The following is a description of a gene set: Cluster d5: genes progressively down-regulated in WS1 cells (fibroblast) through 18 h after irradiation with high dose UV-C. DNA damage caused by UV radiation initiates cellular recovery mechanisms, which involve activation of DNA damage response pathways, cell cycle arrest and apoptosis. To assess cellular transcriptional responses to UVC-induced DNA damage we compared time course responses of human skin fibroblasts to low and high doses of UVC radiation known to induce a transient cellular replicative arrest or apoptosis, respectively. UVC radiation elicited >3-fold changes in 460 out of 12,000 transcripts and 89% of these represented downregulated transcripts. Only 5% of the regulated genes were common to both low and high doses of radiation. Cells inflicted with a low dose of UVC exhibited transcription profiles demonstrating transient regulation followed by recovery, whereas the responses were persistent after the high dose. A detailed clustering analysis and functional classification of the targets implied regulation of biologically divergent responses and suggested involvement of transcriptional and translational machinery, inflammatory, anti-proliferative and anti-angiogenic responses. The data support the notion that UVC radiation induces prominent, dose-dependent downregulation of transcription. However, the data strongly suggest that transcriptional repression is also target gene selective. Furthermore, the results demonstrate that dose-dependent induction of cell cycle arrest and apoptosis by UVC radiation are transcriptionally highly distinct responses. studied in species Homo sapiens from publication Gentile M, Latonen L, Laiho M (PMID 12907719) Human Gene Set: GENTILE_UV_RESPONSE_CLUSTER_D5, and this is the list of marker genes: FERMT2, PXDC1 (NCBI Gene Id 221749), PIKFYVE, TLK2, LBR, PKP4, JMJD6, UBTF, DLX2, PNO1, MRFAP1L1, DUSP11, ZFP36L2, MLX, MPHOSPH6, DYRK1A, FGF5, PITPNB, SRSF3, WBP1L, SS18, STAM, MAML1, VEGFC, ZHX3, NCOA3, TARDBP, UBE2N, NAV3, ATP6V1B2 (ATPase H+ transporting V1 subunit B2), LHFPL2, FADD, HOXB2, FOSL2, SRF